Given this list of marker genes DLG4, SNTG2, NRXN3, NRXN2, NRXN1, here is a description of the gene set: Binding to a member of the neuroligin protein family, neuronal cell surface proteins that mediate synapse formation. Human Gene Set: GOMF_NEUROLIGIN_FAMILY_PROTEIN_BINDING studied in species Homo sapiens